The following is a description of a gene set: Genes predicted to be targets of miRBase v22 microRNA hsa-miR-6867-3p in miRDB v6.0 with MirTarget v4 prediction scores > 80 (high confidence targets). species: Homo sapiens from publication Chen Y, Wang X (PMID 31504780) Human Gene Set: MIR6867_3P, and this is the list of marker genes: RGCC (regulator of cell cycle), TMOD2, TTC19, TNFRSF13B, SESTD1, SLC14A1, SPEG, CDK5R1, PCM1 (NCBI Gene Id 5108), ZEB1, SOX11, LIFR, CD300A, SMG7, HOXB7, BARX2, NPVF, TIAL1, EN1 (engrailed homeobox 1), HS1BP3, RAB44 (RAB44, member RAS oncogene family), C22orf46P, KCNMA1, ADIPOR2, GTPBP2, ATXN7, ZBTB4, FAM170A, PLEKHG7, KRBOX4, EFCAB14, TP53INP2, MAP1A, ELOVL3, EMX2, RPL36A, GPR173, EPAS1, ZNF589, EDN1, UBA5, HOXD13, ASIC1, TRIQK, ZBED10P, KPNA4, ZNF99, TMEM121B, LYRM9, BSN, AGAP1, DUSP6, ENPP3, APLN, HOMER1, SRSF1, KMT2A, PPP1R1A, EPC1, KCNQ3, RABEP1, E2F3, EDEM1, KDM3B, CCR2, FOXK1, TIE1, CR1, ZFP1, FAM120C (family with sequence similarity 120 member C), PI4K2A (NCBI Gene Id 55361), ZNF37A, WSCD1, ARMC9, STMN1, SEC22B, RAP2A, ZNF343, STK38L, DTX4, ACSM2A, NFASC, ESRP1, IFRD1, GLI3, GPATCH2L, PMEPA1, RAB4A, TRIB3, TMEM39A, ZNF440, TGFB3, EFEMP2, GPRC5B, B3GNT5, TRHR, HMGA2, NUP88, PTGER3, ENPP1, VAPB, GPR161, CSPG4, ACSM2B, TLCD4-RWDD3, CPD, PRAME, TAGAP, MGAT5, ZNF135 (NCBI Gene Id 7694), RBL2, STRIP2, RETREG1, STYK1, PPP1R8, MAP2K4, SRP54